The following is a description of a gene set: species: Homo sapiens Human Gene Set: GOBP_REGULATION_OF_GAP_JUNCTION_ASSEMBLY Any process that modulates the frequency, rate or extent of gap junction assembly., and this is the list of marker genes: HOPX, ACE2, IL1B, TBX5, CNTNAP2, APLNR, CAV1, ACE, AGT, IRX3